Given this list of marker genes THBS2, CCN4, LXN, ADGRL2, SCG5, ID3, ID2, PRG4, IFI27, BRINP1, COL6A3, POSTN, ID1, NID1, HSD11B1, PDGFRA, HOXC6, PGF, RARRES1, EBF2, here is a description of the gene set: Human Gene Set: MOROSETTI_FACIOSCAPULOHUMERAL_MUSCULAR_DISTROPHY_UP studied in species Homo sapiens from publication Morosetti R, Mirabella M, Gliubizzi C, Broccolini A, Sancricca C, Pescatori M, Gidaro T, Tasca G, Frusciante R, Tonali PA, Cossu G, Ricci E (PMID 17761758) Facioscapulohumeral muscular dystrophy (FSHD) is the third most frequent inherited muscle disease. Because in FSHD patients the coexistence of affected and unaffected muscles is common, myoblasts expanded from unaffected FSHD muscles have been proposed as suitable tools for autologous cell transplantation. Mesoangioblasts are a new class of adult stem cells of mesodermal origin, potentially useful for the treatment of primitive myopathies of different etiology. Here, we report the isolation and characterization of mesoangioblasts from FSHD muscle biopsies and describe morphology, proliferation, and differentiation abilities of both mesoangioblasts and myoblasts derived from various affected and unaffected muscles of nine representative FSHD patients. We demonstrate that mesoangioblasts can be efficiently isolated from FSHD muscle biopsies and expanded to an amount of cells necessary to transplant into an adult patient. Proliferating mesoangioblasts from all muscles examined did not differ from controls in terms of morphology, phenotype, proliferation rate, or clonogenicity. However, their differentiation ability into skeletal muscle was variably impaired, and this defect correlated with the overall disease severity and the degree of histopathologic abnormalities of the muscle of origin. A remarkable differentiation defect was observed in mesoangioblasts from all mildly to severely affected FSHD muscles, whereas mesoangioblasts from morphologically normal muscles showed no myogenic differentiation block. Our study could open the way to cell therapy for FSHD patients to limit muscle damage in vivo through the use of autologous mesoangioblasts capable of reaching damaged muscles and engrafting into them, without requiring immune suppression or genetic correction in vitro. Disclosure of potential conflicts of interest is found at the end of this article. Genes up-regulated in FSHD (facioscapulohumeral muscular dystrophy) mesoangioblasts.